Given this list of marker genes IFT140, EP300, NPAP1, GNAT2, KMT2B, SMAD4, TCTN2, HERC2, GATAD2B, KIAA0753, CACNA2D4, COL4A1, LCA5, NYX, RPE65 (NCBI Gene Id 6121), CABP4, FKBP6, EMC1, PIGO, SYNE1, P4HTM, DPF2, NBAS, CACNA1F, STX1A, YME1L1, MKRN3 (makorin ring finger protein 3), SYT1, BLTP1, TMEM98, PCDH15, KANSL1, LRMDA, MFRP, SNORD116-1, AIPL1, RAD50, PPP1R12A, PDGFRB, GDF6, PIGW, PIGT, TOMM7, GRM6, KCNAB2, ZMYM2, YY1, PDE6C, TASP1, ERMARD, SKI, NMNAT1, GPR179, SLC25A24, MYT1L, WDR35, FGF3, RPL10, OTUD5, SIN3A, SRRM2, PIGV, KRT5, CEP78, PRSS56, CAPRIN1, ESPN, TRPV4, AHDC1 (AT-hook DNA binding motif containing 1), SLC24A1, FOXL2, PDE6H, LAS1L, MAGEL2, ALDH1A3, PCYT1A, CNGB3, LAMA1, VPS37D, CASZ1, BUD23, PRR12, ARSG, ADGRL1, TULP1, CRB1, TCEAL1, ADNP, PGM2L1, FZD5, CNOT3, CLRN1, UQCC3, CRELD1, SATB2, SIX6, PRDM16, ZNF148, MED12, KERA, CCDC47, B3GAT3, WAC, HSPG2, EPRS1, CLIP2, POMT2, CENPT, NEK1, MSX2, MAN2B1, WDR19, IMPDH1, USH1G, GJA5, SRCAP, ATF6, APC2, RPGR, OPN1LW (opsin 1, long wave sensitive), TRPM1, MADD, WDR26, GJA1, LRAT, RNU4-2, PAX2, POGZ, GNB2, LIMK1, NFIX, RPGRIP1 (RPGR interacting protein 1), CDH23, IFT43, IFT172, TUBB4B, GTF2I, BEST1, USP9X, CSTA, CNGA3, CREBBP, KIDINS220, IQCB1 (NCBI Gene Id 9657), KDM5C, GUCY2D, CHAMP1, GNB3, CACNA1G, NSD1, GRK1, IARS2, PBX1, RD3, CNNM4, EIF4H, OPN1MW, KIF11, PIK3R1, MARK3, FAM111A, COL11A2, BAZ1B, KAT8, NOG, ITPR1, ACBD6, OTX2, PGAP2, UFC1, RAI1, RAX, METTL27, ASXL3, TNPO2, SATB1, SLC6A8, ASH1L, HNRNPR, BLOC1S3, PCNT, PGAP3, LMBRD2, PIEZO2, ZFX, TAF4, SETBP1, MBD5, FLCN, PACS2, DYRK1A, FGD1, KIFBP, GJA8, RERE, TBC1D23, HIVEP2, COL3A1, SOX2, ELN, TMEM270, OGT, USP45, NCF1, PLOD1, HDAC8, CHD3, PDE6B, TGM5, ARV1, ERCC6, FKTN, KCNJ13, MAN1B1, USH1C, IFT52, PPM1D (protein phosphatase, Mg2+/Mn2+ dependent 1D), POLR3A, DNAJC30, GNAT1, CTNNB1, SLC39A8, SETD5, PWRN1, RDH12, KMT2C, RAP1B, RS1, RRAS2, RAB11B, SLC6A6, BCL11B, PRPS1, KAT5, PIGL, CHST3, LUZP1, GABRD, CRX, ATP6V1A, PRKCZ, LTBP2, UBAP2L, PQBP1, HUWE1, RORA, SNORD115-1, RMRP, IFT122, RFC2, FBXO11, SPEN, PDE4D, SHOC2, CTCF, MYO7A, SAG, GTF2IRD2, CLCN3, KRT14, CLP1, ZC4H2, MT-TS2, ATP6AP1, RHO, SON, WDR45, PIGY, PWAR1, PHIP, GTF2IRD1, MED12L, CHMP1A, IQSEC2, ERCC8, SOBP, CLDN11, CSGALNACT1, PDPN, LRIT3, MED13L, CIB2, SPATA7, CAMSAP1, MED25, CEP290, SNRPN, MAG, PUF60, ROBO1, EHMT1, DNAJC21, NADK2, B4GALT7, PIGG, TAOK1, HNRNPK, BICRA, PIGU, CLDN16, UBE4B, TBL2, DDX6, HARS1, MMP23B, NR2F1, H4C5, here is a description of the gene set: studied in species Homo sapiens Hypermetropia Human Gene Set: HP_HYPERMETROPIA An abnormality of refraction characterized by the ability to see objects in the distance clearly, while objects nearby appear blurry.